Given this list of marker genes Fchsd2, Sec61a1, Plxnc1, Pfdn2, Cables1, Parp3, Neurod1, Cxxc5, Mbd3l2, here is a description of the gene set: from publication Chen Y, Wang X (PMID 31504780) Genes predicted to be targets of miRBase v22 microRNA mmu_miR_196a_1_3p in miRDB v6.0 with MirTarget v4 prediction scores > 80 (high confidence targets). Mouse Gene Set: MIR_196A_1_3P species: Mus musculus